Given this list of marker genes B2m, Psen1, Ldlr, Chrna7, Apoe, Fus, Hspg2, Pfdn1, Trem2, Cd36, Camp, App (amyloid beta precursor protein), Cstb, Pfdn5 (NCBI Gene Id 80400), Clu, Iapp, Pfdn6, Tardbp, Cdsn, Pfdn2, Mdm2 (NCBI Gene Id 69330), Serf1, Nup153, Cryab, Ripk1, Usp8, Ripk3, Pfdn4, Gsn, Vbp1, Cdkn2a, Snca, Mapt, here is a description of the gene set: studied in species Mus musculus Mouse Gene Set: GOBP_AMYLOID_FIBRIL_FORMATION The generation of amyloid fibrils, insoluble fibrous protein aggregates exhibiting beta sheet structure, from proteins.